The following is a description of a gene set: from publication He P, Lim K, Sun D, Pett JP, Jeng Q, Polanski K, Dong Z, Bolt L, Richardson L, Mamanova L, Dabrowska M, Wilbrey-Clark A, Madissoon E, Tuong ZK, Dann E, Suo C, Goh I, Yoshida M, Nikolić MZ, Janes SM, He X, Barker RA, Teichmann SA, Marioni JC, Meyer KB, Rawlins EL (PMID 36493756) Human Gene Set: HE_LIM_SUN_FETAL_LUNG_C2_PRE_PDC_DC5_CELL pre-pDC/DC5 species: Homo sapiens, and this is the list of marker genes: ORC6, VRK1, TFDP1, SHQ1, RPUSD4, RUVBL1, SMC2, TRERF1, LILRA1, CEP78, MAD2L1, CEP20, LIN52, DCTPP1, NSD2, GPR180, CXCR3, MATK, ARV1 (NCBI Gene Id 64801), HOMEZ, FEN1, C11orf24, EOLA2, TMIGD2, CDYL, TIFA, TPX2, UBE2S, MCM7, MX1, EIF1AY, PPM1K, DTX2, ACAP1, STX18, ZNF714, SLC1A4, SCT, NUCB2, UBA5, SVIP, MAGOHB, LRRC47, DTYMK, TMEM63A, CDCA8, MTG2, DNAJA3, MNAT1, GPX7, TOP1MT, ACAT2, MAP3K7, SUN2, AHI1, MAIP1, CDH23, CSF2RB, CFAP119, OXCT1, LEMD3, TUBG1, MTM1, HTR3A (NCBI Gene Id 3359), RCN2, GEMIN7, ALG14, HSPA13, CCDC167, CYYR1, LIMA1 (LIM domain and actin binding 1), RAD51C, BARD1, KNTC1 (NCBI Gene Id 9735), SIGLEC6 (NCBI Gene Id 946), NT5DC2, LAS1L, CIB2, DHFR, LMNB2, FBLN1, LILRA4, GPR146 (G protein-coupled receptor 146, NCBI Gene Id 115330), NREP, INPP4A, SMC6, PRXL2A, YARS1, SUZ12, LANCL1, CDH1, NUDT17, SLC2A6, SAAL1, ALCAM, SMC4, ASB1, BCL7A (NCBI Gene Id 605), GEMIN2, RFC3, RPL39L, UPF3B, RAD17, HIVEP2, ITGB3BP, PHF19 (PHD finger protein 19), BRI3BP, PARP10, NUP37, OBI1, SMN2, DAXX, RAVER1, DUS3L, SMYD3, TRMT13, ERCC6L2, SUSD1, GTF2E2, UGCG, UNG, H2AC13, PPP1R14B, CALCRL, PKIG, PIGQ, WDR5, AGK, SERF1A, CDC23, SRD5A3, PPP1R35, HELLS, SLC15A4, LLGL2, TCF3, RRP9, DNAJC9, RMI2, BTLA, YEATS4, GMCL1 (germ cell-less 1, spermatogenesis associated), RHOF, RAB7B, KEAP1, CCNB1, COQ4, CCP110, ELAC2, ZMYM5, SLC7A5, METTL13, ELP6, UBE2T, ZNF296, IDH3A, EOLA1, CENPM, MCM4, PLCB3, NOP2, SIGLEC5 (NCBI Gene Id 8778), CTSW, MCM3, MRPL39, CENPF, RFC5, CENPP, COQ5, CYP51A1, KMO, WDR43, TSPOAP1-AS1, MAG, KCNMB1, GTF3C5, SMARCD1, YRDC, BRCA2, CDCA4, H2AC16, AKAP8, UGDH, MDFIC, ALMS1, PCCB, ARMC6, KCTD5, INPP5B, POLR3K, SMPD3, CD22, AREG, MTERF2, ATAD2, CES1, STRBP, DPF2, H2AX, GPATCH11, ODF2, CDC14A, TOPBP1, ZNF326, TNNI2, MYO9A, FANCI, MVD, FARS2, PTDSS2, TIPIN, IL18R1, GATD1, TPM2, ACOT7, GLRX5, H2AC14, AP3M1, MPHOSPH6 (NCBI Gene Id 10200), TOP2A, DMAC2, ABHD10, USP11, PITPNA-AS1, CENPU, PRMT7, GUF1, NOL10, SULF2, GGH, DKC1, UBR7, IRF4, RIPOR2, FAM98B, ZNF414, RACGAP1, ENDOV, FMC1 (NCBI Gene Id 154791, formation of mitochondrial complex V assembly factor 1 homolog), ANKMY2, SPDL1, PMM2, CDKN2AIPNL, AHCTF1, CSTF3, NIPSNAP1, TSR1, PMS1, NIBAN3, ACSL3, SLC17A9, CD320, GAPT, ATAD3B, ZNF830, HMMR, NFAT5, PSMA2, RCCD1, PPP2R5D (NCBI Gene Id 5528), RAD1, NTHL1, BCL11A, CD7, MCAT, ASF1B, METTL2A, INTS15, BIRC5, CCDC69, LTB, ZDHHC17, SNCA (synuclein alpha), PPM1J, NIBAN1, SAP130, PDLIM1, JCHAIN, CLSPN, GALNS, PCNA, RASSF7, ADGRG5, RYBP, RNASEH2A, NCLN, CYFIP2, SEMA7A, STK26, DBR1, COG7, KIF17, SLC12A2, LMNB1, TPGS2, C1GALT1C1, EPHB1, NUP88, TSTD1, PRC1, RAD51AP1, THEM4 (thioesterase superfamily member 4), TYMS, RASD1, NR2C2AP, FAM107B, SIT1, OPN3, RHEX, NTAN1, ZEB1, PDCD2L, S100B, ADK, PGM3, BEND6, SPIB, TSPAN13, AVEN, RPAP2, CCNB1IP1, MCRS1, CD38, VRK2, ZNF444, HEMK1, IGF2BP1, GMPPB, CDK1, SLAMF7, CDCA7, CEP131, ANKRD39, NGLY1, CENPN, SERF1B, NRF1, NCAPG2, GADD45A, SHCBP1, REXO4, RCAN3, URI1, FBLN2, DDX11, SARS2, UPK3A, LIG1, PAM16, TSEN54 (NCBI Gene Id 283989), HAUS1, TDP1, MED20, MYBL2, OCIAD2, CCNA2, POLR1G, GNG7, MYL6B, PRIM2, CD200, CHAF1A (chromatin assembly factor 1 subunit A), PCED1B (NCBI Gene Id 91523), METTL2B, CD2AP, SAMD9L, CPSF3, IMMP1L, LTK, MSH2, PRORP, CBFA2T3 (CBFA2/RUNX1 partner transcriptional co-repressor 3), ATAD3A, NUSAP1, MCOLN2, NUP54, IARS1, KCNE5, POLR3A, CDC6, CDKN2D, PDSS1, BANK1, CPLANE1, CD2, ENHO, RPIA, ACTL6A, KLHDC4, MTA1, SACS, XXYLT1, CTPS1, POLA2, ZNF789, ADA, RRAGC, GTPBP3, PUS1, UTP23, HAMP, CLEC4C, ZBTB45, HMBS, SLC2A1, CENPW, CBX5, CCNB2, TMEM138, FRY, NPM3, APP, CXXC5, SCN9A, SPATS2 (spermatogenesis associated serine rich 2), NT5DC1, IL3RA, ADAM19, PRPS1, LIME1, PFKP, DAPK2, SMPD2, MYO1E, LY9, MZB1, SUV39H2, SLC5A6, CDK2, IGKC, GINS2, NDRG1, PALD1, CMAS, SEL1L3, SPNS3, ITGB7, PRMT5, ARHGEF3, MAGED1, DCPS (decapping enzyme, scavenger), MRPS10, ASPM, CLECL1P, UBE2C, UBFD1, ST3GAL2, PLAAT3, TUBB6, CKS1B, SLC20A1, RAB29, SH2D3C, CDT1, NCAPG, MKI67, SLC39A6, PPP1R14A, MRTO4, DYNC2I2, TRDMT1, PRPS2, HMGB3, NKG7, ACAA2, ICMT (NCBI Gene Id 57087), UHRF1, CNTROB, GPRC5C, PIGO, C12orf75, SLC38A1, CARHSP1, SLC2A4RG, RDH14, ARL6IP6, FBXO41, HMGCS1, PTPRCAP, AAR2, SLC27A5, MND1, NOP16, GON7, RUNX2, KRI1, FLT3 (NCBI Gene Id 2322), IGSF8, CYB5B, TFAP4, PYCR2, LPCAT4, RAD9A, ST3GAL4, MCM6, ST14, CNP, GMNN, LRR1, CYB561A3, TIFAB, ATP6V0A2, CCDC34, GNG11, CCDC146, DOLPP1, NUFIP1, NCBP2AS2, NIPA2, PPP3CC, PCLAF, PAICS, FUZ, LRRC40, RRS1, GALNT3, NOP14, A1BG (alpha-1-B glycoprotein), TRAF4, PHGDH, PIDD1, DTL, EZH2, EBNA1BP2, C19orf48P, PXMP2, EBP, TRAF2, CMSS1, DHTKD1, GMPS, ZNF669, KIF11, MCM2, UQCC4, RRM1, CDCA7L, EXOSC3, ASF1A, PTTG1, EXOSC9, MIX23, LINC00665, PRIM1, MAP4K1, CARD11, DERL3, CLIC3, SMN1, LSG1, ZNF639, MT2A, TEDC1, CENPH, NUP160, DIDO1 (NCBI Gene Id 85362), NAPSA, CEP95, CCDC51, BCL2, STRN3, ZWINT, GPATCH4, ERG28, TXLNG, ATAD5, ST6GALNAC4, HIRIP3, RIOX2, TBCC, SNAI1, LTV1 (LTV1 ribosome biogenesis factor), PTS, PTPN7, CDC20, ZFAT (NCBI Gene Id 57623), MIS18A, CENPK